The following is a description of a gene set: from publication Hervas-Stubbs S, Riezu-Boj JI, Gonzalez I, Mancheño U, Dubrot J, Azpilicueta A, Gabari I, Palazon A, Aranguren A, Ruiz J, Prieto J, Larrea E, Melero I (PMID 21108462) studied in species Homo sapiens IFN alpha mediated gene expression pattern. The effect of IFN alpha on human CD8 T cells responding to antigen (signal 1) and costimulatory signals (signal 2) provided by beads coated with anti-CD3 and anti-CD28 mAbs. This analysis examined the effects of IFN alpha on human CD8 T cells responding to antigen (signal 1) and costimulatory signals (signal 2) provided by beads coated with anti-CD3 and anti-CD28 mAbs. Magnetically sorted untouched CD8+CD45R0- T cells from three different donors were unstimulated or stimulated with IFNa2b or with anti-CD3/CD28 Beads alone or along with IFNa2b or IFNa5 for 48 hours. Individual mRNA samples were analyzed using HG-U133A 2.0 array gene chips. Human Gene Set: GSE17301_ACD3_ACD28_VS_ACD3_ACD28_AND_IFNA2_STIM_CD8_TCELL_UP Genes up-regulated in CD8 T cells activated by anti-CD3 and anti-CD28 versus those stimulated by IFNA2., and this is the list of marker genes: MLF2, STK11, KMO, CHST10, TOP2A (DNA topoisomerase II alpha), CLSTN1, SMARCC1, YBX1, PFAS, BRIP1, DNTT, BMP3 (bone morphogenetic protein 3), KHSRP (NCBI Gene Id 8570), GLI1, TTF1, ALDH7A1, PRKAR2B, USP13, INKA2, NCAPH, SLC25A3, PDIA6, RARS1, GPRC5A, SKP2, ALG12, LAGE3P1, PXMP2, PSMA6, RAD54L, U2AF2, CASKIN2, RAD23A, CA9, ATP2A1, THOC5, DCLRE1B, TLR7, GUCY1B1, SSBP3, TMT1A, GRSF1, MIR622, SPC25, RFC4, PIMREG, GSR (NCBI Gene Id 2936), MYO19, PRRG3, MCM3AP-AS1, POLD2, MAP1S, NME8, ZNF556, CXCL1, HLA-DPA1, TNFRSF21, TREML2, NAA50, WIZ, LCN2, TMEM131L, PSMA4, SERP1, ATP1B3, CD320, HCFC1 (host cell factor C1), PRSS50, COLQ, LRRC17, CX3CR1, SEMA3B (semaphorin 3B), TP53I3, RGS2, ZNF282, TRIM2, C11orf16, ACYP1, TRMT5, MFHAS1 (NCBI Gene Id 9258), GAB2, HYAL3, NDUFB3, NBEAL2, SMCO4, METTL2B, ARHGAP33, CLGN, ABCF2, H4C13, GPR25, SNRPA, FAIM, TUBG1, HCCS, TERT, BTF3, MYB, PCDHB11, RUFY3, FAM153A, AURKA, MS4A6A, SORT1, SRSF10, UVRAG, SERPINF2, MICAL3, ECHDC1, ZWILCH, MSH6, SCN4A, YWHAE, ZSWIM1, GRK2, CHST11, REPIN1 (NCBI Gene Id 96712), LST1, ACSBG1, FAM53B, CIAO3, GK, GNAO1, HINT1, KRI1, FCN3, BCAT2, H2AZ1 (H2A.Z variant histone 1), NDST3, CNTNAP1, GLRX5, RUBCNL, GATM, KIF18A, GABRA4, G6PD, STMN1, RND1, IDH2, TRAIP, BRCA1, H2AC16, CEP70, DNAJC9, TBC1D5, CYC1, GSE1, NOC4L, RPS7, GTF2A1, POLE, TBC1D10B, EZH2, GLO1, CTSG, MGLL, POLD1, GPI, MRM2 (NCBI Gene Id 29960), CD99, HSPBP1, CC2D1A, GLUD2, SLC43A3, TK1, DPEP1, MCM3, PLK4, BAG2, RAB4A, CCNE2, FNTB, CAMK1G, KANK1 (KN motif and ankyrin repeat domains 1), POLR3C, HNRNPU, HMGB2, H2BC9, TFDP2, CARHSP1, NINL, MKRN7P, APOC4, NOX3, E2F5, DEPDC1, GNGT1 (NCBI Gene Id 2792), ATAD5, ZNF592, METRN, LPAR4, CLUH, OTUB1, SCCPDH, MRPL3 (NCBI Gene Id 11222), VAC14, PRKDC, BUB1, LGALS1